Given this list of marker genes ITGA1, NRP1, ITGB1, CNTN6, CHL1, ITGA10, ANK1, ITGA2, HSPA8, here is a description of the gene set: Human Gene Set: REACTOME_CHL1_INTERACTIONS species: Homo sapiens CHL1 interactions